Given this list of marker genes TMEM241, SEPHS1, CASK, MEIOSIN, DPP10, KHDRBS2, GABPA, LYPLA1, GNA11, RBM24, ENC1, IL24, GOLGA4, ZBTB11, GEM, CDKN1C, HIC2, OVOL1, EFHC2, CEMIP, NR3C1, TIMM17A, SPHKAP, AFG1L, RAB27A, LGALSL, ATP2A2, TMEM259, AK9, RCAN2, ZNF396, GIGYF2, IFNG, SPDYE5 (NCBI Gene Id 442590), JAZF1, GCFC2, NEUROG2, DAAM1, ELMOD2, ATL2, SNAPC1 (NCBI Gene Id 6617), SLC25A11, CREBRF, CCNJL, PTF1A, SEC22C, SPDYE1, PTS, PKN2, CHMP3, ZNF529, COX11, IPO7, SYNE3, CCNE2, UNC119B, G3BP1, ANKRD42, EEIG2, TOM1L1 (target of myb1 like 1 membrane trafficking protein), TMTC1 (NCBI Gene Id 83857), ATXN7 (ataxin 7), UNC79, FREM1, TBX4, WIPF1, DEPDC1, DYNLRB2, SMIM13, FEZF2 (NCBI Gene Id 94016), NCKAP5, VCAN, FBXO8, ST3GAL5, GK5, RANBP6, GARIN1B, CRHBP, VAMP7, ARL5B, PELI1 (pellino E3 ubiquitin protein ligase 1), FAS, IL10, SIVA1, B3GALT2 (NCBI Gene Id 90195), SLC17A6, TMEM53, PLXNC1, BDNF, DHPS, NUP188, COLCA1 (NCBI Gene Id 399948), EBF2, LRRC4, FAM72C, ZFYVE28, TMCC2, KATNBL1, PDS5A, IKZF2, AIDA, MECP2, ZNF519, CYTH1, LHX6, TNK2, TRIL, MSI2, PHACTR2, FRS3 (NCBI Gene Id 10817), SKIL, TSHZ2, SENP2, KCTD9, IL2, ZNF362, MLLT3, MTX3 (NCBI Gene Id 345778), PDE3A, POU3F1, KCNK1, DRD1, PRDM16, AGFG1, HYOU1, FEM1B, EPHA7, CDKN2AIP, GABPB1, EGR1, IFT81, EPHA3, SLCO1A2, DENND5A, ADAMTS4, ALDH1A2, C8orf34, RAB43, PABIR3, TAOK1, ZNF709, CLDN8, PLEKHA6, ZBTB20, ALG10B, CACNA1C, MXD1 (MAX dimerization protein 1), IQCB1 (NCBI Gene Id 9657), AMPH, MCMBP, C2CD2L, ASB5, TRPC1, H1-8, DNMT3B, CCK, CD164, SP7, MORC3, IGHMBP2, CDK19, KCNH7, TNF, AKAP10, SEMA3F, POU3F2, TBCCD1, NEDD4L, GPC3, GALK2, SIKE1 (NCBI Gene Id 80143), ZBTB1, LZTS1, PDE6D, SLC37A4, SLC35D1, GPR37, KCNAB1, CD109, SKP2, PHF8, FZD6, LPP, SKI, FBXO28, NR2C1, RBP4, C12orf75, ZNF804A, ZEB2, FMNL2, CAGE1, ZNF334, WWTR1, SCYL1, RNASEK, MAP2, RAP2B, GSE1, FERMT2, EVC2, UTP14A, RNF19A, KCNMB2, FURIN (NCBI Gene Id 5123), EFCAB14, SUZ12, MAML2, GNRHR, SRGAP2, THAP11, VSTM4, CHD6, TMEM163, RADIL, CUX1, LEPROTL1, USP25, RUNX2, AJAP1, PPFIBP1, SULT1E1, PIBF1, CAMSAP2, TRPM8, NT5DC3, MON2, ZFAND1, MPHOSPH9, JKAMP, PCMTD1, DDX5, TXNDC15 (NCBI Gene Id 79770), AHCTF1, CPEB2, ANKRD12, ITPRIPL2, OSTF1, ZNF454, AGRN, PAQR5 (progestin and adipoQ receptor family member 5), TNRC6A, HELZ2 (NCBI Gene Id 85441), ARMT1, TWIST1, ZNF705D, SIN3B, ARHGAP5, ACTR3, BEND4, PLPPR4, GABRB2, MAP3K10, EML2, RHOQ, ATL3, TMEM267, EHF, UGT1A10, PAK4, ANKIB1, MITF, LDB2, TCIM, NAV2, H2AZ2, CPNE8, GNB4 (NCBI Gene Id 59345), MAP2K4, SGCB, SSX2IP, TUBE1, BAZ2B, IL17A, EDNRB, DTD2, SPPL3, ITGA3, CNOT7, ATXN1, UMPS, TNFRSF11B, LDLR, ELL, SS18L1, CSF3, SDC4, GLIPR1L2, EPHA4, XPR1, CD200R1, ELP1, NXT1, SATB2, UGT1A6, NUP58, PLEKHG1, EPC1, KIF1A, INTS6, COL25A1, FAM131A, UNC5C (unc-5 netrin receptor C), AZI2, DYRK1B, RYBP, TNFSF9, ZBTB10, PIAS3, EGLN1, SOX6, GPATCH1, RAP1GAP, ARL15, PARP9, CDKN2D, RSKR, TPGS2, JAM3, CDC73, PRRC1, IGFBP5, ISY1-RAB43, LATS1, ZNF600, DSC2, ASAP2, CYTH3, ASPH, PAPSS2, MBTPS2, CEP85L, EAF1, LRCH4, TBL1X, CD24, FNBP1L, ITCH, ZNF680, SPDYE3, NALCN, HOOK3, RSPO2, GLRB, RARG, PICALM, MTHFD2L, BTBD1, MEX3A, USF3, BIRC6, ERLIN2, DHX15, CSRNP3, ACVR1B, CETN3, LSAMP, PCF11, ANKRD52, KIAA1328, GPALPP1, P2RY13, IFNA1, SRSF10, DROSHA, ZNF705EP, ZFPM2, OSBPL3, IL22RA2, RXRA, CD274, COG6, ARSJ, KCNB1, SLC7A1, PIGN, AKAP11, DVL2, SGK1, CREB5, TPST2, NDUFB4, TVP23C, ABHD13, HSPA5, HSPH1, SPART (NCBI Gene Id 23111), A4GNT, COL12A1, ROBO1, NEUROD1, EIF5A2, MAP1A, MAP7D1, CCL20, CKAP2, CEP97, SULT4A1, UBE2D1, PUM3, FRS2, F3, MET, C1orf146, DCUN1D1, SMURF1, CAMK1, NEDD1, SLC23A2, SLC30A7, GABRA4, ELAVL3, NRARP, LRAT, LARP4, SHH, MAPK6, STAM2, PRDM1, BNC1, ABCC9, POMGNT1, KLHL42, RASGRP3, VGLL3, MECOM, SYNPR, TYRP1, DGKH (diacylglycerol kinase eta), SIPA1L3, ACVR2A, SDC2, SESN3, HS3ST5, ACSBG1, SYP, SPDYA, SLC30A8, RPTOR (NCBI Gene Id 654218, regulatory associated protein of MTOR complex 1), DNAJB14, RET, SCAF4, WNT1, COQ10B, HNRNPA2B1, STRN4, PRPF40A (NCBI Gene Id 55660), CCNY, NAIP, LYRM7, DESI1 (NCBI Gene Id 91610), IL1RAP, KLHL7, PRICKLE1, TXNDC8, SDE2, JCAD, DNAJB12, RNF103-CHMP3, GRM1, ABL2, WDFY3, FKBP7, PPP2R5B, PHF12, FAM72A, FAM72B, RGPD4, RAB5A, FAM72D, HIF1A, USP9X, MAFB, MAPK9, ZNF365, CDR2, ARID3A, PROM1 (NCBI Gene Id 9634), SATB1, AKNA, UGT1A9, PPP3CC, PTBP2, APPL2, ATXN7L1, CACNA2D2, MBNL3, ADM, ABTB2, IFRD1, KIF21A, TTC9, PPM1B, IFFO2, SLC25A17, COL2A1, FZD2 (NCBI Gene Id 2535), LRCH2, EEA1, TESK2, PAFAH2, ZNF850, MOB1A, RBM18, SGK3, LIF, DIXDC1 (NCBI Gene Id 85458), SMURF2, MPPED2, ATP8B1, TPRG1L, MBOAT2, WWP1, SLC2A13, CBX7, ASB7, STIM2, TBC1D2B, SLC30A1, SGCZ, GNAQ, ARHGAP17, PIK3CA, CALHM5, DIMT1, NAA16, LRATD2 (NCBI Gene Id 157638), REV1, DMXL2, PDE1A, NTRK2, SEMA3C, ELAVL1, DNMT3A, SLC35G1, TRAPPC11, ZNF793, KAT2B, ATP13A3, CCDC88C, MALRD1, TWF1, BPTF, COLGALT2, PTGER3, RAPH1, TOX2, ST6GALNAC3, KMT2C, COX8A, RINT1, PRTG, SPTSSA, CREBL2, SLC16A9, SLC39A1, AVIL, MSX1, PDE2A, FAM8A1, CXorf38, CSRNP2, PHF20, SUCO, ZMAT3, BRPF3, NAPB, SAMD4A, SEC63, MTMR11, PGF, NUF2, ZNF705A, PRR12, ZSWIM4 (zinc finger SWIM-type containing 4), TMOD2, MEIOC, SCRT2, ENTPD7, ABCA13, DPH6, ARL1, RIMKLB, MPZL1, CYBRD1, KIF5B, SRPX, TBC1D9, TRIP13, LMO7DN, DAAM2, HYCC2, ABCB7, DUSP19, ATP11B, TMX3, IP6K3, DCAF5, JUNB, PDGFC, EXPH5, EOGT, ZNF641, NSMAF, CNOT6L, ZNF85, PABPC5, TCF21, IRS2, PGBD5, B4GALT3, BOLA3, ANO5, IL9, GSKIP, CSF1, LRP12, SPDYE6, TBPL1, VWC2, ZC2HC1A, FHIP2A, TRIB2, FBXL3, ALDOB, CD44, APOO, TPH1, MOSPD1 (NCBI Gene Id 56180), SMAD2, KANSL1, PANK4, ITGA7, ZNF597, CBFB (NCBI Gene Id 9163), CDC42SE2, ABT1, KDM7A (lysine demethylase 7A), YIPF6, TMEM39A, SCN3A, KRTAP19-3, CHD9, PHF14, EPC2, TVP23B, here is a description of the gene set: Genes predicted to be targets of miRBase v22 microRNA hsa-miR-3121-3p in miRDB v6.0 with MirTarget v4 prediction scores > 80 (high confidence targets). Human Gene Set: MIR3121_3P species: Homo sapiens from publication Chen Y, Wang X (PMID 31504780)